The following is a description of a gene set: species: Mus musculus The chemical reactions and pathways involving ATP, adenosine triphosphate, a universally important coenzyme and enzyme regulator. Mouse Gene Set: GOBP_ATP_METABOLIC_PROCESS, and this is the list of marker genes: Prxl2c, Pklr, Stat3, P2rx7, Ak5, Ndufa8, Ldhd, Eno3, Hspa1b, Ndufa10, Mlst8, Prkaca, Fis1, Psen1, Pgam1, Pfkl, Pkm, Prkaa1, Dmac2l, Gck, Abcc9, Nudt2, Ppp2ca, Hdac4, Ndufb4, Ndufa9, Hkdc1, Ndufb6, Trim63, Ppara, Zbtb7a, Ndufb10, Tgfb1, Ak2, Pfkm, Antkmt, Trem2, Nupr1, Adpgk, Ppargc1a (NCBI Gene Id 320239), Tkfc, Ddit4, Vcp, Mlxipl, Esrrb, Nt5e, Pfkfb3, Tspo, mt-Nd1, Atp5mg, Ndufa5, Atp5mc2, Igf1, Slc4a4, Nudt5, Abcc6, Trex1 (three prime repair exonuclease 1), Dnajc30, Ndufs7, Ins2, Arnt (aryl hydrocarbon receptor nuclear translocator), Aldoart2, Ndufv3, mt-Nd4 (NCBI Gene Id 98546), Aldoart1, Slc25a25, Atp5pf, Prkag2 (NCBI Gene Id 73700), Ep300, Myh6, Mpi, Myh8, mt-Nd4l (mitochondrially encoded NADH dehydrogenase 4L), Sdhb, Atp5if1, Ndufs1, Atp5f1d, Col6a1, Pfkfb1, Dhtkd1, Prkag1, Hif1a, Ndufs8 (NCBI Gene Id 225887), Map2k1, Mfsd8, Sdhc, Eno1, Pid1 (NCBI Gene Id 98496), Ucp2, Atp1a2, Uchl1, Foxk2, Slc25a12, Ndufc2, Atpsckmt, Atp5mc1, Ndufa1, Gapdhs, Htr2a, Khk, mt-Atp8, Eno4, Ndufv1, Prkn, Ndufs6, Flcn, Ak1, Pgam2, Prkaa2, Cox11, Ndufa12, Ndufab1, Actn3, Atp5f1e, Atp5f1c, Pfkp, Ndufc1, Foxk1, Aldob, Atp6-ps, Ifng, Atp5mf, Ampd2, Mtor, Gpd1, Ndufb5, Atp5f1b, Hk1, Uqcc3 (ubiquinol-cytochrome c reductase complex assembly factor 3), Il3, Ndufa2, Git1 (NCBI Gene Id 63992), Bloc1s6, mt-Nd5, Atp6v1b2, Gale, Ndufb1, Parp1, Tigar, Ier3, Aldoc, Src, Nmnat1, Galt, Atp5po, Bcl2l1, Ndufb11, Stoml2, Eno1b, Ndufb7, Gapdh, Ndufb9, Sirt6, Ndufb8, Ndufa11, Atp5pb, Fam3a, Letmd1, Bad, Atp7a, Fbp1, Gapdhrt, Aldoa (aldolase A, fructose-bisphosphate), Atp1b1, Atp6v1a, Ncor1, mt-Nd6, Myog, Adcy10, Ndufb3, Zbtb20, Ogt (O-linked N-acetylglucosamine (GlcNAc) transferase (UDP-N-acetylglucosamine:polypeptide-N-acetylglucosaminyl transferase)), mt-Atp6, Ctns, Pgk2, App, Enpp1, Ndufb2, Atp5f1a, Sphk2, Galk1, Fkrp, Bpgm, Entpd1, Ndufs3, Ndufa7, Hk3, Kat2b, Ogdh, mt-Nd3, Lipa, Prkag3, Sdha, Ola1, Clpx, Slc25a13, Parg, Pfkfb2, Ndufs4, Rptor, Fignl1, Atg5lrt, Dnm1l, Ndufa13, Arl2 (NCBI Gene Id 80563), Selenon, Pgk1, Slc2a6, Tpi1, mt-Nd2, Ndufs5, Ins1, Mlx, Eno2, Bend3, Ak4, Eif6, Bcl2l13 (NCBI Gene Id 94044), Atp6v1b1, Insr (NCBI Gene Id 319666), Gpi1, Sdhd, Hk2, Tmsb4x (thymosin, beta 4, X chromosome), Ampd3, Jmjd8, Hspa8, Gapdhrt2, Ndufs2, Ndufa3, Atp5me, Enpp3, Sik2, Atp5mc3, Ak3 (NCBI Gene Id 56248), Myh7, Cfh, Atp5pd, Slc4a1, Myc, Ldhc, Il4, Myh3, Ndufv2, Mtch2, Hnf1a, Cbfa2t3, Ndufa6